Given this list of marker genes BLMH, DPEP1, HNRNPA3, NUAK1 (NCBI Gene Id 9891), GAS2L3, GRAMD1A, SPRY1, CLIC1, OLR1, R3HDM1, FBLN1, SPP1, KCNU1, SNTG1, COL6A3, INPP5D, STK39, ANGPT1, HUNK, NT5DC2, ASAP2, B3GALT2, ZC3HAV1L, MYO1D, SULF1, PHYHIPL, NRP2, RASGRF2, F13A1, TRPS1, MCTP1, THBS2, ANTXR1, HIP1, ILF3, DLGAP5, LAMC1, GLS, ARID3A, HK2, SEMA3C, STC1, NCAPD2 (non-SMC condensin I complex subunit D2), KIT, COL4A2, COL1A2, TGFB2, COL1A1, DTL, TNC, ANXA1, ITGA2, PIEZO2, RNASE1, OLFML2B, GRK3, MME, NCAPH, NCAPG, SMARCC1, COL12A1, RRM2, NPM1, PTPN14, IGF2BP1, MYO5A, CDK4, RAP2A, HTR1D, COL4A1, CDK1, PLD3, HSPG2, COL2A1, SGO1, CPA6, UACA (uveal autoantigen with coiled-coil domains and ankyrin repeats), PRKDC, ACSL4, UGGT1, CHD3, IGF2BP2, BMP4, PDGFRB, MS4A2, ITGA8, LGR5, NUP93, BCL9, NOTCH3, RHOBTB1, ROBO1, FOXM1, ADAM9, BAMBI, GNA12, BCAT1, BCAM, PARPBP, RACGAP1, HMGB2, LAMB1, TSPAN13, NKD1, CCL18, TBX3, CD34, ESM1, CHST11, IGSF1, PRC1, PRKAA2, EDIL3, FAP, DYNC1H1, TCF4, GREB1, RERE, RPS3A, SLC1A5, SLC38A11, TNFRSF19, TXNIP, PTK7, AXIN2, MAP4K4 (mitogen-activated protein kinase kinase kinase kinase 4), TRIB2, RPS12, DEPDC1, VCAN, ZSWIM5, PLCG1, CREB3L2, CDH11, TACC1, FMNL2, SLIT3, CDKN3, CKAP2L, SMOC2, CDK6, MTBP, MAP1B, MGAT5, DNMT3A, PLXNC1, MGP, TMC7, KIF18A, MMP16, ODAM, RPL8, CDH13, SLC7A6, TRIM71, ZNRF3, CACNB4, VWF, SLC7A11, COL15A1, DHX9, LAMA4, here is a description of the gene set: Genes hypomethylated and overexpressed in hepatoblastoma (HB) tumors as compared with non-tumor (NT) adjacent tissue assessed by Infinium MethylationEPIC 850K array and Human Transcriptome Array 2.0 & RNA-sequencing. Background & Aims: Hepatoblastoma (HB) is a rare disease. Nevertheless, it is the predominant pediatric liver cancer, with limited therapeutic options for patients with aggressive tumors. Herein, we aimed to uncover the mechanisms of HB pathobiology and to identify new biomarkers and therapeutic targets in a move towards precision medicine for patients with advanced HB. Human Gene Set: CARRILLOREIXACH_HEPATOBLASTOMA_VS_NORMAL_HYPOMETHYLATED_AND_UP species: Homo sapiens from publication Carrillo-Reixach J, Torrens L, Simon-Coma M, Royo L, Domingo-Sàbat M, Abril-Fornaguera J, Akers N, Sala M, Ragull S, Arnal M, Villalmanzo N, Cairo S, Villanueva A, Kappler R, Garrido M, Guerra L, Sábado C, Guillén G, Mallo M, Piñeyro D, Vázquez-Vitali M, Kuchuk O, Mateos ME, Ramírez G, Santamaría ML, Mozo Y, Soriano A, Grotzer M, Branchereau S, de Andoin NG, López-Ibor B, López-Almaraz R, Salinas JA, Torres B, Hernández F, Uriz JJ, Fabre M, Blanco J, Paris C, Bajčiová V, Laureys G, Masnou H, Clos A, Belendez C, Guettier C, Sumoy L, Planas R, Jordà M, Nonell L, Czauderna P, Morland B, Sia D, Losic B, Buendia MA, Sarrias MR, Llovet JM, Armengol C (PMID 32240714)